The following is a description of a gene set: Human Gene Set: WP_OMEGA6FATTY_ACIDS_IN_SENESCENCE Omega-6-fatty acids in senescence species: Homo sapiens, and this is the list of marker genes: PRXL2B, CYP4F8, LTA4H, MAPK11 (mitogen-activated protein kinase 11), CYSLTR1 (cysteinyl leukotriene receptor 1), TBXA2R (thromboxane A2 receptor), NAT2, FADS1, FADS2, PTGES3, HPGD, GGT5, GSTP1, PTGIS, DECR1, PTGES, ALOX12, DPEP1, PTGER1 (NCBI Gene Id 5731), EPHX2, ALOX15, ALOX15B, GPX1, PLA2G4A, AKR1C3, TP53, ELOVL2, PTGR2, PTGIR, SLCO2A1, PTGS1, CBR1, CDKN1A, PTGFR, PTGER3, RB1, PTGER4, PTGDS, PTGS2, ABCC4, TBXAS1, ALOXE3, ELOVL5, PTGES2, ALOX5, DPEP2, PTGDR, PTGER2, HPGDS, SIRT1, GGT1, SERPINE1, PTGDR2, ALOX5AP, LTC4S, ALDH1A1, AKR1B1 (aldo-keto reductase family 1 member B)